The following is a description of a gene set: studied in species Homo sapiens An abnormal union between bones or parts of bones of the upper limbs. Synostosis involving bones of the upper limbs Human Gene Set: HP_SYNOSTOSIS_INVOLVING_BONES_OF_THE_UPPER_LIMBS, and this is the list of marker genes: ZIC1, FKBP6, MLXIPL, NIPBL, NXN, CTBP1, TCF12 (NCBI Gene Id 6938), IHH, MASP1, COL27A1, BUD23, GTF2I (general transcription factor IIi), TBX15, TMEM270, HOXD13, GSC, B3GALT6, RBM8A, SMC3 (structural maintenance of chromosomes 3), SMC1A, TWIST1, DYNC2LI1, FGF9, EIF4H, CLIP2, NSD2, SMOC1, MAP3K7, VPS37D, SMAD6, ELN, RIT1, RRAS (RAS related), TBL2, PRKACA, NCF1, CHSY1, BRD4, RASA2 (RAS p21 protein activator 2), B3GAT3, TBX5, CBL, RPL26, ANAPC1, WNT7A, SHH, MYH3, LIMK1, BAZ1B, KAT6B, TFAP2B, BICRA, SOS2, EIF4A3, MAF, PQBP1, XYLT1, PRKACB, PAX3, METTL27, HDAC8, RFC2, FLNA, NRAS, UBAP2L, SPRED2, MECOM, SOS1, HOXA11, DONSON (NCBI Gene Id 55597), PTDSS1, NOG, FBLN1, STX1A, PIEZO2, GTF2IRD1, GTF2IRD2, PTPN11, RAF1 (Raf-1 proto-oncogene, serine/threonine kinase), APC, FGFR1, CSGALNACT1, FGFR2, B4GALT7, GDF5, ATP7A, RAD21, HOXA13, MRAS, FGFRL1, CPLX1, PITX1, CYP26B1, BCOR, KRAS, DNAJC30, GLI1, CANT1, ROR2, EVC2, MACROH2A1, LZTR1, LETM1, LRP4, BMPR1B (NCBI Gene Id 658), FGFR3, DHODH, POR, FLNB, SF3B4, TAF6, FGF16, EVC, CHST3, COLEC10, SETBP1, NONO (non-POU domain containing octamer binding), RECQL4 (NCBI Gene Id 9401), SALL4, ESCO2, TBX22, BPNT2, RRAS2, BHLHA9, LMBR1, COLEC11